Given this list of marker genes Pomt2, Mgat5b, Slc35a4, B3galnt2, Pomk, Crppa, Dag1, Fkrp, Pomt1, Fktn, here is a description of the gene set: electronically inferred by orthology from the curated human pathway studied in species Mus musculus Reactome Pathway: DAG1 glycosylations part of: O-linked glycosylation This event has been computationally inferred from an event that has been demonstrated in another species.<p>The inference is based on the homology mapping from PANTHER. Briefly, reactions for which all involved PhysicalEntities (in input, output and catalyst) have a mapped orthologue/paralogue (for complexes at least 75% of components must have a mapping) are inferred to the other species.